Given this list of marker genes Met, Sh3rf2, Ednrb, Rassf2, Adrb2, Bak1, Slc46a2, Plxnb1, Cd27, Rnf13, Adora2b (NCBI Gene Id 632506), Prox1, Csnk2b, Ppia, Klb, Tcf7l2, Schip1, Trp53, Ltf, Npy, Tnfrsf11a, Dvl3, Rundc3a, Ankrd17, Prmt1, Fnip2, Vangl2, Dhx36, Nek10, Shoc2, Map2k1, Tns3, Dynlt1b, Pten, Rnf31, Asb15 (NCBI Gene Id 78910), Iapp, Mmp2, Srms, Agr2, Adcyap1, Map3k7, Ksr2, Esr2, Cd8a, Taok1, Malt1, Gucy1a2, Ppp1r15a, Mid2 (NCBI Gene Id 23947), Sesn2, Znhit1, Shc1, Kiss1r, Or2at4, Map3k3, Prkcb, Tfrc, Gpr137c, Phb1, Mios (NCBI Gene Id 97312), Usp15, Bag4 (BCL2-associated athanogene 4), Zdhhc3, Ambra1, Trim13, Naip5, Bmyc, Sct (secretin), Ep300 (NCBI Gene Id 328572), Ptpn2, Xbp1, Birc2, Mink1, Xrcc3, Ccl19-ps5, Casp1, Cav2, Raf1, P2rx4, Thra, Nr3c1, Ptger3, Usp4, Fpr-rs3, Pdgfrb, Lrrk2, Mapre2 (NCBI Gene Id 319531), Akr1c18, Sfpq, Il3, Irs1, Fzd7, Ncoa2, Bmp6, Clec4n, Map3k1, Gadd45b, Erp29, Pdgfa, Adcy10, Dgki, Cited2, Ajuba, Lep, Fgg, Gipr, Tial1 (Tia1 cytotoxic granule-associated RNA binding protein-like 1), Fgf6, Ppp2ca, Bok, Apoe, Nagk, Dusp22, Kiss1, Tenm1, Erbb2, Hdac3, C1qbp, Dusp15, Grm4, Mapk8, Ilk, Htr2a, Ntf3, Ager, Drd5, Col3a1, Pik3cg, Dcc, Esr1 (NCBI Gene Id 13982), Cth, Dcn, Dync1li1, Nmi, Nrg1, Casp4, Gdf6 (growth differentiation factor 6), Trpv4, Bcl2l11, Ret, Smad3, Cd81, Crebbp, Map2k3, Gpr37l1, Pias4, Erbb3, Tifa, Wdfy1, Nodal, Epha4, Ikbkb, Nckap1l, Eif2ak2, Prkd1, Huwe1, Naip6, Rhoa, Prkcz, Traf5, C5ar1, Epo, Mef2c, Ankrd1, Spag9, Marco, Lamtor2, Ppp3r1, C1qtnf1, Klf2, Cx3cr1, Fxr1, Map2k4, Lrrk1, Egfr, Kmt2d, Ptk2, Src, Cxcl12, F11r, Atr, Brcc3dc, Kras, Havcr2, Ank3, Cripto, Pik3cb, Kitl, Adam8, Drd2, Seh1l, Trip6, Rap1a, Smpd3, Ptpn22, Tank, Sstr4, Fgfr2, Ubb, Icam1 (NCBI Gene Id 235038), Map3k20, Irs2, Maged1, Edaradd, Mapkbp1, Irak2, Erbb4, Trim44, Fpr-rs6, Avpi1, Pik3ca, Cd19, Avpr1b, Fgd4, Prag1, Nrk, Trim62, Nppc, Irs3, Usp50, Epgn, Gpr3, Thrb, Npr2, Gpr183, Dynlt1f, Parp1 (poly (ADP-ribose) polymerase family, member 1), Fpr-rs7, Pdgfb, Amh, Prpf4b, Bnip2, Car8, Trim30c, Mapk8ip3, Il11, Clec4d, Irf3, Npsr1, Klhdc10, Tti1 (NCBI Gene Id 98972), Jcad, Gpr137b, Otud5, Tnfsf15, Bmp7, Card11, Nod2, Spop, Bcar3, Rheb, Card10, Nkd1, Adcyap1r1 (adenylate cyclase activating polypeptide 1 receptor 1), F10, Iqgap1 (IQ motif containing GTPase activating protein 1), Myoc, Fgfbp3, Ripk3, Gpnmb, Mup3, Fadd, Rpl37rt, Pik3r1, Il34, Vav3, Fpr-rs4, Zdhhc1, Inhba, Ndp, Abra, Rpl26, Fgf1, Adora2a, 3425401B19Rik, Npr1, Ccdc22, Chd5, Ube3a, Ptbp1, Trp73, Ripk1, Il20ra, Agt, Nts, Zc3h12a, Thpo, Musk, Alkal2, Fgf16, Hfe, Rit2, Casp8, Tnfsf10, Vav2, Sema3e, Slc15a3, Nr3c2, Cbl, Neurod2, Stmp1, Arhgap8 (NCBI Gene Id 73167), Lin28a, Glipr2 (NCBI Gene Id 97132), Pip4p1, Ada, Eef1e1, Tradd, Dusp19, Negr1, Trim30a, Il19, Cd3e, Exoc4, Mos, Nampt, Map3k12, Akt1, Ccl19, Bmp5, Lamtor4, Wnt7b, Stk19, Ptk2b, Eng, Pycard, Ikbke, Dhx33 (DEAH-box helicase 33), Gpx1, Dok4 (docking protein 4), Pdgfc, Arhgef5, Brd4, Fgfr4, Oasl1, Cd74, Lgals9, Gip, Prkd2, Rragd, Arfgef1, Trim30d, Nedd4 (NCBI Gene Id 639396), Itgb1, Ccnq, Igfbp5, Rtn4, Nkx3-1, Tnfrsf1a, Auts2, Cdk5rap3 (NCBI Gene Id 97738), Rxrb, Pros1, Unc5cl, Madd, Hgf, Nppb, Flna, Mapk3, Cspg4, S100a4, Bmp2 (NCBI Gene Id 98992), Tgfbr3, Styxl1, Agrn, Tab1 (TGF-beta activated kinase 1/MAP3K7 binding protein 1), Lpar2 (NCBI Gene Id 53978), Spi1, Mturn, Terf2ip, Gpr137, Plpp3, Hipk2, Fgf15, Smcr8, Vwf, Tnfrsf19, Nek7 (NIMA (never in mitosis gene a)-related expressed kinase 7), Mtch2, Drd1, Pde5a, Abl1, Slc9a1, Dixdc1, Btk, F2rl1 (F2R like trypsin receptor 1), Irak1, Rxfp2, Acta2, Ngf, Tcim, Ucn, Dsc2, Nptn, Ptpn11, Ccl3, Lmo3, Inava, Sctr, Siah1b, Cd24a, Actn4, Igf1, Map4k2, Fgf2, Dok7, Prok1, Nrxn1, Psen1, Ccr1, Sphk1, Bcap31, Gper1 (NCBI Gene Id 76854), Cxcl17, Camk2d, Dlg5, Wdr59, Ltbr, Gpr4, Ifi211, Ddx60, Psap, Drd4, Tlr8, Hcst, Nup93, Tgfa, Ptpn6, Ubd, Rptor, Mapk8ip1, Nod1, Nenf, Ddit3, Sox11, Taok3, Ywhae, Spred1, Adam9, Oprk1, Tlr3, Flt1, Cdc42, Edn2, Gfral (GDNF family receptor alpha like), Notch2, Ins1, Mir205, Igfbp6, Cartpt, Sema7a, Kit, Sash1, Rpl37, Naip1, Rasgrp1, Wwc1, Fgr, Rictor (RPTOR independent companion of MTOR, complex 2), Cd86, Avpr2, Hic1, Rpl23, Coro7, Hspa1b, Rock1, Rps6kb1, Rps15, Ackr3, Fzd5, Il1a, Nrp1, Lrp1, Rgl2, Otud7b, Fasl, Trim55, Pink1, Zc3hav1, Sco1, Pik3r5, Gapdhrt, Egf (NCBI Gene Id 99717), Trem2, Fgf22 (fibroblast growth factor 22), Wnt5a, Spring1, Robo1 (roundabout guidance receptor 1), Ppp5c, Meis3, Prnp, Trim38, Traf3ip2, Slc30a10 (NCBI Gene Id 226781), Sema4c, Plcb1, Dhx15, Lamtor3, Bmp4, Lrrc19, Bax, Ddx3x, Ghrh, Lats1, Ddx1, Calr, Fgfr1, Mup11, App, Sos1, D130043K22Rik, Mtor, Csnk1a1, Ccl19-ps1, Il1r1, Nck1, Vegfb, Kdr, Sh3rf1, Lims1, Klk1b4, Akap5, Adgrg1, Ppp3r2, Bub1, Mas1, Tgfb1, Fabp5, Wbp2, Npnt (nephronectin), Jmjd8, Pum2, Cyct, Pla2g5, Lrp4, Ncoa3, Cd28, Med1 (mediator complex subunit 1), Lamtor5, Htr2c, Rb1cc1, Cd4, Mup1, Ticam2, Ptprc, Fcer1a, Vcp, Srarp, Pdpk1, Necab2, Rc3h1, Pum1, Bmper, Hax1 (NCBI Gene Id 23897), Tirap, Agap2, Tff2, Stk3, Rack1, Pih1d1, Usp17le, Ptpn1, Trim5, Wnt7a, Adrb1, Pdcd4, Mtdh, Cib1, Sox2, Snw1, Ntrk3, Mul1, Pja2, Ccl21e, Fgf21, Npy5r, Ticam1, Mertk, Rbck1, Rela, Dynlt1c, Gucy1a1, Flot2, Fnta, Mydgf, Pagr1a, Rad9a, Fam110c, Gadd45g, Ntrk1, Cd300ld3, Bdnf, Braf, Glce, Itsn1, Ffar4, Wdr24, Rapgef1, Atp2c1, Zap70, Cd44, Lmcd1, Litaf, Crhr2, Gpr39, Mat2a, Trim25 (NCBI Gene Id 22660), Arhgef3, Usp32, Akap13, Arrb1, Pdcd10, Grm5, Peli1, Rc3h2, Rtkn2, Trat1, Slc15a4, Ednra, Cass4, Timp2, Nmnat1, Serinc3, Foxp1, Prl, Stard10, Tek, Gapdh-ps15, Alkal1, Fgf8, Irak3, Fnip1, Slc19a1, Pcid2, Rasd2, Fgf3, Ing4, Ptger4, Tyro3, Mid1, Mst1r, Nck2, Otub1, Clec7a, Cav1, L1cam, Ptp4a3, Ddr2, Usp9x, Traf6, Mir494, Prkca, Atf6, Adora1, Prkce, S100a8, Clu, Tmem100, Sh3glb1, Mt3, Mlst8, Bmpr2, Frmd7, Gen1, Ube2v1, Steap3, Gapdhrt2 (NCBI Gene Id 434330), Btbd10, Adora3, Prxl2c, Vav1, Gpbar1, Ccl5 (NCBI Gene Id 20304), Myh9, Arl6ip5 (ADP-ribosylation factor-like 6 interacting protein 5), Osbpl8, Oprm1, Stk4, Prr5l, Mavs, Lars1, Rasgef1a, Vdr (vitamin D (1,25-dihydroxyvitamin D3) receptor), Trim8, Kcnn4, Ago1, Frmd6, Adra2c, Fgf7, Map2k7, Lta, Prkn, Flot1 (NCBI Gene Id 14251), Ripk2, Ppp3cc, Adam17, Angpt1, Ppard, Chuk (conserved helix-loop-helix ubiquitous kinase), Rac1, Dab2ip, Ar, Trim26, Cul1, Tbk1, Syk, Camta1, S100b, Unc5b, Rell2, Net1, Garem1, Iqgap3, Pla2g2a, Ddx21, Fgf20, Ern2, Bank1, Ccl21b, Bbc3, Rps20, Nox1, Dock2, Lepr, Taok2, Adissp, Spry2, Acvrl1, Pim2, Txn1, Mapk8ip2, Pik3r6, Tab3, Cavin3, Edar, Tnfaip8l3, Traf2, Pdgfd, Cx3cl1, Eif2ak3, Pld2, Fgf18, Akap12, Zfp622, Igfbp3, Gpr55, Sh3rf3, Nqo2, Tbx1, Adipoq, Igf1r, Casr, Hpse, Gas6, Ube2n, Nlrp12, Sema5a, Rxra, Traf4, Trim52, Ndc80, Tnik, Dennd2b, Nelfe, Adra1d, Dhx58, Bcl10, Park7, Fcgr2b, Card9, Rock2, Eda2r, Mad1l1, Tlr6, Aldh1a3, Xdh, Map3k10, Tgfbr1, Twsg1, Fzd10, Atoh8, Rap1b, Tlr7, Il6, Adra1b, Bad, Card14, Tab2, Gucy2d, Mark4, Gpr101, Atat1, Rasgrf1, Cd84, Ogt, Gbp2, Notch1, Birc5, Cherp, Zfp385a, Ccn2, Cdkn2a, C1qtnf2, Ccar2, Hmgb1, Fzd4, Gdf7, Trim12a, Fgf5, Hand2, S100a13, Itgb1bp1, Gdf2, Ccr1l1, Zcchc3, Trim32, Adrb3, Ccl21a, Acvr2a, Mbip, Iqschfp, Pparg, Cntf, Gcnt2, Grm1, Hint1, Frs2, Fgfr3, Tmem106a, Dab2, Il1b, Nr2c1, Hexim1, Rsad2, Jun, Mcl1, Tnip2, Itgb3 (NCBI Gene Id 268495), D1Pas1, Birc7, Ccl19-ps3 (C-C motif chemokine ligand 19, pseudogene 3), Lamtor1, Tgm2, Cyp27b1, Pde8b, Fbxw7 (NCBI Gene Id 68467), Stambpl1, Akt3, Trim15 (NCBI Gene Id 69097), Treml4 (NCBI Gene Id 75989), S100a9, Pik3ap1, Plcg2, Myorg, Ankrd6, Bclaf1, Gsn, Fn1, Grm2, Gab1, Sema4d, Gps2, Ghrl, Nox4, Pmaip1, Tpr, Gm12250, Fshr, Ndrg4, P2ry1, Nmur1, Vegfa, Trim56, Mad2l1, Abca7, Cd40lg, P2ry6, Rps23rg1, Chga, Slc38a9, Gpr155, Nacc2, Pcp4, Tpd52l1, Muc20, Dstyk (dual serine/threonine and tyrosine protein kinase), Mup5, Gsdme, Ror1, Hnf1a, Axl, Reln, Dnajc27 (DnaJ heat shock protein family (Hsp40) member C27), Rbx1-ps, Tasl (NCBI Gene Id 71398), Bmt2, Sharpin, Stk39, Rnf167, Maz, Lurap1, Ifi35, Lats2, Cflar, Ccdc88a, Erfe, Nherf1, Lpar1, Csf1r (NCBI Gene Id 12978), Cxcr4, Htr2b, Nppa, Paqr3, Cul3, Mc1r, Ppp3ca, Fgf10, Lif, Ccl21d, Smad4, Asxl1, Flt4 (FMS-like tyrosine kinase 4), Itpkb, Fgf23, Zeb2, Spred2 (NCBI Gene Id 97717), Ifi204, Wac, Ltk, Tgfb3 (transforming growth factor, beta 3), Akap6 (NCBI Gene Id 238161), Ksr1, Sod1, Hbegf, Calcr, Tlr2, Peli3, Sik3, Myd88, Fyn, Gcg, Ctnnb1, Castor1, Klhl22, Asxl2, Alox15, Lyn, Taf6, Ppp3cb, Bmp10, Tmem33, Serpina12, Serpinf2, Adra1a, Flcn, Skil (NCBI Gene Id 71615), Fbxw11, Pla2r1, Rraga, Adra2b, Pdgfra, Apela, Epor, Pla2g6, Pim1, Zdhhc5, Phb2, Ddr1, Stox1, Gprc5b, Ccr2, Ptprj, Shq1, Mup4 (major urinary protein 4), Ikbkg, Septin4, Ctns, Golph3, Ern1, Tpbg, Ramp3, Fgf9 (fibroblast growth factor 9), Kl, Pde6h, Chp2, Selp, Cdk10, Ei24, Zdhhc9, Mup2, Rwdd3, F7 (NCBI Gene Id 14068), Lurap1l, Alpk1, C1qtnf12, Tnfsf11, Il18r1, Stk25 (NCBI Gene Id 98522), Irak1bp1, Rragb, Mcf2l, C1qtnf3, Dkk1, Igf2, Edn1, Tlr4, Lhcgr, Rnf183, Rragc, Nfat5, Sh2b1, Sirt1, Ins2, Fzd8, Phlpp1, Zbtb7b, P2rx7, Cdon, Insl3, Mif, Csf3, Adgrv1, Chrna7, Prkcd, Rps3, Insr, Plagl2, Peli2, Arrdc3, Brcc3, Laptm5, Map3k13, Cat, Pde6g, Scimp, C1qtnf4, Gapdh, Htt, Cd40, Axin1, Knl1, Jund (jun D proto-oncogene), Mfhas1, Itgal, Prr5, Fbh1, Plscr1, Rps7, Ngfr, Slamf1, Apoa1, Tgfbr2, Adra2a, Prkra, Fgd2, Cdh13, Igfbp4, Picalm, Map4k1, Gnai2, Il18, Atp6v0c, Jak2, Fgf4, Mmd2, Tlr9, Ctbp2 (NCBI Gene Id 52060), Tifab, Edn3 (NCBI Gene Id 13616), Bmpr1a, Wnt4, Skp2, Nlrp3, Ncs1, Ndst1, Itga1, F3, Ccl19-ps4, Taar1, Prdx2, Dvl2, Guca1a, Dok5, Becn1, Cysltr2, Sec13, Efna1, Myc, Ece1, Rbx1, Ntsr2, Fpr2, Bid, Gadd45a, Fgf17, P2ry12, Lpar3, Trim3, Gpr62, Extl3, Osm, Nupr1, Tspyl5, Dnm1l, Csf1, Naip2, Arrb2, Specc1l, Asb3, Msx1, Ryk, Spatc1l, Hcrtr1, Trim30b, Map3k5, Nup62, Tgfb2, Fermt2, Tnfsf14, Gata3, Pml, Rpl11, Foxa1, Siah1a, Thbs1, Ighm, Wnt16, Crh, Epha8 (NCBI Gene Id 230847), Lck, F2r, Fga, Grem1, Ccdc88c, Chi3l1, Xiap, Pde8a, Gdf15, Mn1, Lmnb1, Lilra5, Sos2, Ptgis, Wnt11, Aurkb, Hmgcr, Vnn1, Rell1, Ccl19-ps6, Hcls1, Trim12c, Magi3, Cracr2a, Itgav, Map4k4, Cdca8, Gdf5, Crkl, Lat, Ltb, Gpr37, Fer, Gbp5, Htr6, Fgb, Gdf11, Tnf, Ccl21f, Ntrk2, Crk, Incenp, Ube2i, Aars1, Nlgn1, Traf7, Dynlt1a, Sppl3, Acvr1, Pebp1, Alox8, Rtn4r, Ncam1, Ceacam1, Ccr7, Cd36, Atm, F2, S100a7l2, Map3k11, Il6ra, Abl2, Map3k4, Crhr1 (corticotropin releasing hormone receptor 1), Cpne1, Clec16a, Alox12b, Eda, Ddx5, Pak1, Hras, Map2k6, Ezh2, Rapgef2, Irak4, Sorbs3, Cdh2, Ago3, C3, Synpo2l (synaptopodin 2-like), Fis1, Faim, Ifi205, here is a description of the gene set: Mouse Gene Set: GOBP_POSITIVE_REGULATION_OF_INTRACELLULAR_SIGNAL_TRANSDUCTION Any process that activates or increases the frequency, rate or extent of intracellular signal transduction. studied in species Mus musculus